The following is a description of a gene set: species: Homo sapiens Defective CHSY1 causes TPBS Human Gene Set: REACTOME_DEFECTIVE_CHSY1_CAUSES_TPBS, and this is the list of marker genes: NCAN, CHSY1, CSPG5, VCAN, CSPG4, DCN, BGN, BCAN